Given this list of marker genes GJB6, GJC2, GJD3, GJC1, GJB2, GJA1, GJA5, GJC3, here is a description of the gene set: studied in species Homo sapiens Human Gene Set: GOMF_GAP_JUNCTION_CHANNEL_ACTIVITY_INVOLVED_IN_CELL_COMMUNICATION_BY_ELECTRICAL_COUPLING Any gap junction channel activity that is involved in cell communication by electrical coupling.